The following is a description of a gene set: studied in species Mus musculus Mouse Gene Set: GOBP_CARDIAC_CHAMBER_FORMATION The developmental process pertaining to the initial formation of a cardiac chamber from unspecified parts. A cardiac chamber is an enclosed cavity within the heart., and this is the list of marker genes: Tbx20, Nkx2-5, Notch1, Hand1, Pcdha9, Ednra, Mesp1, Hand2, Tbx2, Smarcd3, Mef2c, Tbx5, Bmp2